Given this list of marker genes KREMEN2, KREMEN1, DKK2, DKK4, DKK1, LRP5, here is a description of the gene set: LRP5 is subject to an in-frame missplicing event in breast and parathyroid cancers that renders the protein insensitive to inhibition by the WNT antagonist DKK1. Expression of the mutant protein results in elevated levels of active, unphosphorylated beta-catenin and enhanced TCF-dependent WNT-signaling, promoting cellular proliferation. Reactome Pathway: Signaling by LRP5 mutants species: Homo sapiens part of: Signaling by WNT in cancer